The following is a description of a gene set: species: Homo sapiens Human Gene Set: HP_METABOLIC_ACIDOSIS Metabolic acidosis Metabolic acidosis (MA) is characterized by a fall in blood pH due to a reduction of serum bicarbonate concentration. This can occur as a result of either the accumulation of acids (high anion gap MA) or the loss of bicarbonate from the gastrointestinal tract or the kidney (hyperchloremic MA). By definition, MA is not due to a respirary cause., and this is the list of marker genes: SLC7A7, WNK4, GK, NFS1, GATM, MRPS28, POLRMT, PCCA, PRDX1, FBP1, CAD, UQCRC2, LRPPRC, GATA3, MT-ATP8, FBXL4, ALDOB, GLYCTK (NCBI Gene Id 132158), NDUFS7, MRPL3, NFU1, MCCC1, KLHL3, EHHADH, CLDN16, KYNU, GALT, RRAGD, VIPAS39, CYC1, CYP27B1, UQCC2, NDUFS1, SLC2A2, CLCNKB, NEUROG3, RRM2B, NDUFAF1, UQCRB, NADK2, UPB1, TANGO2, BCS1L, ATP6V1B1, GCSH, NDUFAF8, ACAT1, MCEE, NDUFAF6, LYRM4, LARS2, IVD, DLD (dihydrolipoamide dehydrogenase), PIGA, PLVAP, SCO1, NDUFA9, JAG1 (jagged canonical Notch ligand 1), AUH, STX3, AARS2, DEF6, COA8, NDUFA6, UQCRH, IFT56, MTO1, ACADM, UMOD, ATP6V0A4, MT-TN, RYR1, PDHA1, GCDH, COX6B1, NDUFAF4, OCRL, IBA57, CA5A, COX14, NDUFA2, HNF4A, MLYCD, CTNS, SCNN1G, SLC34A1, PAX2, GRHPR, ALDH6A1, GSS, APRT (NCBI Gene Id 353), HSD17B10, PCCB, TAOK1, SLC12A3, NR3C2, NDUFB11, HMGCL, LCT, MCCC2, HIBCH, SLC25A3, COA6 (NCBI Gene Id 388753), ERCC6, NDUFB10, MMAB, AGXT, SCNN1A, HADHB, CPT1A, PHKB, SLC4A4, CLMP, SUOX, VPS33B, EPG5, MMUT, PPA2, PHKG2, TUFM, SLC4A1, ACADS, KCNJ5, PLPBP, CA2, HNF1B, NDUFS2, NDUFV1, NDUFB8 (NCBI Gene Id 4714), PHKA2, SLC25A19, BTD, SURF1, DPYS, FH, SLC37A4, HPD, PET100, CUL3, RBCK1, ACADVL, SCO2, MRPS22, CPT2, POLG2, SLC52A1, MMACHC (metabolism of cobalamin associated C), MMAA, COX10, HMGCS2, PC, PBX1, MPV17, MT-TL1, OGDH, PDHX, INVS, MYO5B, SLC5A1, FAH, CACNA1S (calcium voltage-gated channel subunit alpha1 S), WNK1 (NCBI Gene Id 9872), HLCS, FOCAD, NOTCH2, PNPO, SCNN1B, RMND1, GFM1